Given this list of marker genes B4GALT1, NNMT, FN1, S100A9, DDX3X, CHP1, TNC, ITGB6, TWF1, MCL1, CDK17 (cyclin dependent kinase 17, NCBI Gene Id 5128), G3BP2, CLIC4, CDV3, TP63, PCDH7, COPA, SRSF6, CCND2, THBS1, NUP188, MMP3, DHX9, NUP160, here is a description of the gene set: from publication Azare J, Leslie K, Al-Ahmadie H, Gerald W, Weinreb PH, Violette SM, Bromberg J (PMID 17438134) species: Homo sapiens Human Gene Set: AZARE_STAT3_TARGETS The persistent activation of signal transducer and activator of transcription 3 (Stat3) is a common feature of prostate cancer. However, little is known about the Stat3 targets that may mediate prostate tumorigenesis. The introduction of an activating mutant form of Stat3 (Stat3-C) into immortalized prostate epithelial cells resulted in tumorigenesis. Stat3-C-expressing cells had decreased E-cadherin levels, increased numbers of lamellipodia and stress fibers, and enhanced migratory capacities compared to vector control-expressing cells, with a concomitant increase in the expression of integrin beta6 and its ligand, fibronectin (FN). Exogenously added FN increased cellular migration, with a concomitant loss of E-cadherin expression. The blockade of integrin alphavbeta6 in Stat3-C-expressing cells inhibited migration, increased E-cadherin levels, and reduced colony formation in soft agar. These results demonstrate the sufficiency of constitutively activated Stat3 in mediating prostate tumorigenesis and identify novel Stat3 targets that are involved in promoting cell migration and transformation. Genes up-regulated in RPWE-1 cells by activated STAT3.